The following is a description of a gene set: Human Gene Set: ZNF664_TARGET_GENES species: Homo sapiens from publication Yevshin I, Sharipov R, Kolmykov S, Kondrakhin Y, Kolpakov F (PMID 30445619) Genes containing one or more binding sites for (ZNF664) in their promoter regions (TSS -1000,+100 bp) as identified by GTRD version 20.06 ChIP-seq harmonization., and this is the list of marker genes: SMG7, FSBP, SEPHS2, IFNAR2-IL10RB, HMGXB4, TSR2, CCDC65, SVBP, TRIM44, DPY19L4, UACA, GNAO1 (G protein subunit alpha o1), CAMSAP1 (NCBI Gene Id 55490), PPP1R12A, FDPS, POMT2, IMPACT, HCFC2, DENND2B-AS1 (DENND2B antisense RNA 1), DNMT3B, KIF9, STAT2 (NCBI Gene Id 6773), VMAC, DAGLB, RABGGTA, DOC2A (NCBI Gene Id 8448), INSYN2B, LAG3, RNU4-60P, PLAC1, PI16, INAVA, ALDH3A1, TTLL13, MRPL11, CTSB, HOMER1, PDRG1, TATDN2, CYFIP2, BICDL2, NHSL3 (NHS like 3), DHX9, JAK2, NUP37, PTGES3L-AARSD1, EHHADH-AS1, CLASP2 (cytoplasmic linker associated protein 2), VEPH1, LAMP1, LINC00431, PRSS23-AS1, LINC02028, NUTM2B-AS1, FTO, TIA1 (TIA1 cytotoxic granule associated RNA binding protein), TFDP2, ZFYVE27, RHEBP2, CCSAP, EFCAB13-DT, LINC02522, LINC01641, TAF15, LIPM, POLK, IFTAP, LYPLAL1-DT, GBA1, LINC02860, EXOSC2, ARHGAP40, LINC00682, CACYBP, KDM5C, TNRC18, ARHGEF12, VRK1, VEGFA, CNOT10, PI4K2A, RNF114, GADD45GIP1, PAFAH1B1, WASHC2A, CGNL1, MRPS31, TTYH2, MIR5696, MIR1273C, TERF1, NLRC5, ARHGAP26 (NCBI Gene Id 23092), CLDN23, FABP5, LINC00845, CHD9, CEP350, RN7SL241P, STON2, CCAR2, CCNL1, MIR615, LMBR1L, ZNF827, RALGPS2-AS1, RALA, HIRIP3, IFI6, RAB35-AS1, PCAT6, DCTN1, EMC9, GXYLT2, TMPRSS6, ZNF408, MTG2, ZNF565, ZNF609, TSPAN31, GALNTL5, DLEU1, ELFN1-AS1, PSMD3, MLST8, EPS8L1, GTPBP3, ANKRD18B, GABARAP, RAX2 (NCBI Gene Id 84839), UTP23, PHF3, PRPF40A, LINC02044 (NCBI Gene Id 101929717), SPMIP10, NFYC, SYNGR1, ODAD4, CAMK1, ABLIM2, CFAP97D1, NCOA2, GOLPH3L, ZNF263, PDE2A, INTS14, NRBP1, HOXC12, LMO4, RPL32P18, EGLN2, ACOX2, PTCH1, CDKAL1, COX6B2, FRMD4B, WEE2-AS1, ERICH1, HAPLN2, DSE, OSBPL3, DNPEP, PCDH12, ADAMTS14, RAB5A, SMCHD1 (structural maintenance of chromosomes flexible hinge domain containing 1), IFI35, YAE1, LINC02435, LHFPL2, PBX1, DDX5, TRIM62, OR1X5P, TRUB2, SSX2IP, MAPK4, SCN4B, LNROP, BEGAIN, B4GALNT1, MECR, RAPGEF3, CRISPLD2, BORCS6, PEAK1, TTYH1, GRPEL1, NOL12 (nucleolar protein 12), SPAG5, CELF1 (NCBI Gene Id 10658), TJP3, PHC2, AQP8, RPUSD2, EYA2, PDK2, DEFB124, HADH, HMGN2P15, CHD2, USP3, STX8 (syntaxin 8), PDZRN3-AS1, CAMK2G, ENSG00000181123, CHEK2, RERE, IGDCC3 (NCBI Gene Id 9543), COPS3, TIMP1, TPM4, IGFL4, TMEM167A, ARHGEF2, AP3B2, PAM16 (NCBI Gene Id 51025), GMNC, RPSAP10, KLHDC9, LINC00940, SERTAD3, KAT8, LMNA, CD160, HERPUD1, RHEBP1, DAPP1, LIF-AS2, RAB27A, DNHD1, CACNG5, LAMTOR5, PFKFB4, RPP25L, OCSTAMP, SMAP2, RPS6KC1, BCL10, BCL7C, DOHH, ENSG00000255428, CERT1, ITGA7, RBMS1, HACD3, GAPDHS, EIF3F, LIPA (NCBI Gene Id 3988), CARD8-AS1, CAMSAP2, COX16, PDE4A, ADD3, FZR1, LTBP4, MDGA1, PRPSAP2, SNORD96A, MIR4799, ATP23, CDC42EP4, FN1, KDM5B, NEK7, MAN1C1, HNRNPR, SEC22B, CHORDC1, CROCCP3, GRM8, CCNG2, SEC22C, IGSF23, ARHGAP23, GDAP1, PTGR2, MEI1, ZNF865, KIF12, TOR1A, LRP10, ISY1, RNU2-17P, PYY, RBM14-RBM4, SUB1, MED25, HMGA2-AS1, CREBRF, HMGN3-AS1, CWC15, RAI14, GTF2E1, ARL2BP, CALCOCO2, ANKRD13C, ATF2, RN7SL443P, CAPZB, CCDC168, ARHGEF10L, KLHDC8A, SNX27, LINC00963, SLC12A8, PNPLA6, MIR6124, PGAM1P5, TMEM253, TMEM128, SEZ6L2, PADI2, TEFM, DAZAP1, MECOM, TIMM17A, MIR99AHG, TRIM59, NOSIP, MTMR4, DAPK3, KCTD3, CLASP1, SRSF10, TNFRSF12A, CREM, CLN6, SH2B3, FRG1, BRMS1L, CDK17, CHRM4 (NCBI Gene Id 1132), USP30, RRAS2, TOR1AIP2, CCNQ, ADGRV1, MAP1S, ZMAT2, CBFB (NCBI Gene Id 9163), FBXO17, SLFN12, GANC, SBF2, QSER1, FAM174B, SGSM1, PRMT1, DTNA, EPHB6, TBC1D4, CPD (carboxypeptidase D), ENSG00000236366, SRP54-AS1, MTA3, COG5, ZMPSTE24, EIF3I, SMG8, FANCD2, LNMICC, TRAF3IP2-AS1, MRPS15, SOS1, SLC5A5, PGF, LINC01116 (NCBI Gene Id 375295), WDHD1, NEK2-DT, ANO1, LIG1, WDR24, MYB, H2AZ2, SLC15A3, LMO1, MAT2B, ZNF503-AS1, RHEX, ST7-OT4 (NCBI Gene Id 338069), FNDC4, SAMD8, ATP6V1G2, TTC1, JAKMIP1, MICOS10-DT, COPS5, ACTN4, SLC4A9, TAF6L, OLFM1, EPB41L2, CNNM4, MAPK6, PDCD11, KDM1B, RPL18, ST7, C11orf58, FBXO31, DHRS13, IQCN, BRWD1, LINC02229, NEURL1B, RNU7-29P, MTUS2, PPL, CLEC2L, LNCRNA-IUR, CD276, MGC16275, GNAO1-DT, WSCD1, TOR2A, SCUBE1, DR1, OMG, DCAF11, TMEM234, GTF2H4, GLT8D2, HIF1A, STX4, CARD10, RNF150, CEP95, PLEKHM1, NLGN1, MACF1, SPACA4, CEBPB-AS1, FHL1, PHB1P18, RILPL1, STRN3, ABHD6, XPR1, ATRX, PLA2G1B, NIPA1, RUNDC1, EPS15, PRKCI, TMED2-DT, C19orf25, CHD7, CDC5L, FUZ, ATP5F1C, RPL36, ZDHHC7, RBM39, ENSG00000265246, TSNAX, C14orf132, SYNDIG1L, GAS8, ANKIB1, C16orf96 (chromosome 16 open reading frame 96), PML, MRPL39, FOXM1, PLXDC1, HEXA-AS1, FAM20B, CATSPERD, RBBP6, OPA1, ZNF579 (NCBI Gene Id 163033), MIR5003, LINC01503, RNU6-821P, CDC42SE1, PRPF40B, SEMA4B, HES4, ITSN1, CXADR, CWC25 (NCBI Gene Id 54883), PLEKHB2P1, SLC25A53, C16orf95-DT, KAAG1 (kidney associated DCDC2 antisense RNA 1), CTNNBIP1, LINC00856, MAGED1, ZNF277-AS1, WFIKKN2, BSPRY, FMN2, LINC00173, GABRD, NDUFA11, COL17A1, ENPP3, HMGA2, ALAD, ZC3H13, CCDC9, AGTRAP, MAPKAP1, ISLR2, ARHGAP24, GLMN, MTFMT, IL16, CXorf38, MIR4425, RASAL1, BLM, KIFAP3, NOL6, TXNRD2, MAPK14, SLC39A13, GBA1LP, ADAP2, XKR8, AFG3L2 (NCBI Gene Id 573970), PLLP, TMCO4, RND1 (Rho family GTPase 1), PHOSPHO1, MRPS21P6, TSHZ2, ANKRD31, MEF2A, PLEKHA7, CPVL, LINC01944, GLIPR1L2, PALLD, SEPTIN7P14, HMG20A, CARD8, RACK1, LYPD3, MPRIP, GMDS-DT, FUBP1, PTGES3L, GIT2 (GIT ArfGAP 2), SNHG16, URI1, VLDLR-AS1, OSTN, FAM181B, MYH14, TMEM98, RN7SL417P, LUZP1, MTFR1L, TARS2 (NCBI Gene Id 80222), KLHL36, LNCATV, AATF, PRMT5, SH2B1, PPP2R2A, FRMPD2, TLCD5, SLC9A6, PAXBP1, NR2F1-AS1, TRIB3, TUBA1C, NUTM1, SRFBP1, BPNT2, IFT74, ENSG00000260592, TMEM260, ZBTB43, MOV10, C3orf38 (NCBI Gene Id 285237), TMEM44-AS2, RNU2-33P (NCBI Gene Id 106480211), MRPS18CP6, DTX1, GPR132, RDH8, WASF4P, NTF4, VPS39, SDC4, ZNF596, ASB11, SCAPER, TPCN1, LINC01298, EEF1A1, ACSS2, CALM2, GLO1, STX12, NDUFB2-AS1, SUPT4H1, PHYH, GNPAT (glyceronephosphate O-acyltransferase), GDF15, PIGBOS1, PLN, VPS33A, CYTH4, FBXW8, HNF4A, CLK3, ELF3, HECTD4, HDAC5, ARL2-SNX15, STK19, AKR1B1P1, RPL32P27, LINC01411, ALDH9A1, NRL, PTX3, SMG7-AS1, LOXL2-AS1, ECE1, RHOF, SERAC1, PHGDH, UPF1, LYRM9, POLQ, WNT8A, C2orf42, PLXNC1, STK4, TLE2, LRRC51, RNF149, GALNT9, AP3S2, CYB5R3, PLA2G4C, ANK2, MIR4487, LIM2-AS1, SORBS1, KDM1A, RLIM, WWP2, SVIP, DCP2, DBF4B, TM7SF3, THYN1, KMT2C, MANSC1, RAB3D, UFC1, NOP2, RANP5, ZC3H18, RN7SL734P, EPCIP-AS1, PEX19 (NCBI Gene Id 7835), ZBTB38 (zinc finger and BTB domain containing 38), HPS6, ITPR1 (NCBI Gene Id 619543), RPL23AP53, ZNF296, KCTD9 (NCBI Gene Id 54793), RAP1GAP, EGFLAM-AS1, TNNI1, IL17B, LINC00921, TRAV41, LINC01270, STRA6, SRSF12, C2-AS1 (C2 antisense RNA 1), ITGAL-AS1, PIK3R2, NAPSA, PFDN1, NOS3, A1BG, SF3A3, GABPB2, ZSCAN23, BLOC1S1, SIPA1L3, CASP9, SLC4A1AP, DYNC2I1, ABCA7, TRAF4, LYPD5, TNKS1BP1, ANKRD34A, SPCS2P4, GLG1, CCDC91, KCTD17, TMED2, SYVN1, ZYG11A, REV3L, CHMP3, FABP5P3, MIR608, SAMTOR, MANEAL (mannosidase endo-alpha like), NAGA, ADGRA3P1, SMAGP, THORLNC, MRTFB, RPS26, MFN2, LCP2, PDLIM4, REEP3 (NCBI Gene Id 221035), SNORD48, C16orf92, CORO1C, SMG1P7, RPL37, DOCK9, CAPN2, ARHGAP1, PCBD1, FAM20A, WDR11-DT (NCBI Gene Id 283089), SRC, TPMT, MAN2A1, ENSG00000244137, NFASC, TM9SF4 (NCBI Gene Id 9777), COMMD5, CEBPG, RN7SL209P, SHLD2P1, DNAJC7, SPRYD3, AJUBA-DT, TMEM87A, MIR5700, ABRACL, OPA3, DIRAS2, TGFB1, CD151, DDHD2, RAPH1, LOXL2, PDHB, DPRXP1, KCNK1, EXOC3, RGS22, ARHGEF19, HEXA, ZNF473, STK10, RABGAP1L-DT, C1orf131, CNOT6L, LTBP3, CDCA2, SNHG32, VPS41, RNF24, ADAM9, EFCAB7, ANO8, CRYM, EIF4G1, EFCAB14, AMFR, NOVA2, TTI2, GPR62, NR3C1, ENSG00000269172, MFSD14A, DNAH14, HNRNPMP2, SINHCAF, SLC38A1, C9orf78, SSBP2, ERCC1 (ERCC excision repair 1, endonuclease non-catalytic subunit), SPAG17, SMAD9, BBS7-DT, CALCRL-AS1, STAT6, TMEM248, LINC02453, NUCB1-AS1, ENG, LINC02687, REXO5, C9orf50, THUMPD3-AS1, GOLGA3, GREM2, TMC8, FGD6, ECE1-AS1, DPP9, ACER3, KLRK1, CUL2, ALDOA, SPINK2, ADA, RAD54B, MED21, SHC4, TENT5B, ISY1-RAB43, EXOSC3, RNU6-22P, MIR5092, SLC20A1, WDR11, ARHGAP18, USP6NL, LINC00910, TRIM15, CGGBP1 (NCBI Gene Id 8545), CCNI (NCBI Gene Id 10983), HCG27, LINC01132, EPB41, CASP8, ZBTB20-AS1, GTF2H5, FAM222A, TRIM9, WWC1, SNHG30, LYPLAL1, ZMPSTE24-DT, LINC02794, CDK5RAP1, ERAP2, RNU6-166P, MIR554, RPS14, ME2, SULT2B1, CHIC1 (cysteine rich hydrophobic domain 1), ENTPD4, CDA, MGST2, NDUFS7, SPATS2L, ADAR, SCFD2, SLC25A17, TSNAX-DISC1, SYNGR3, TAF1A-AS1, GON4L, TIAM2, TTC3, CFAP61 (cilia and flagella associated protein 61), VTA1, SPHK2, AJUBA, PHF21A, NUP42, ABHD17A, ZNF302, SPATS2, HNRNPD, FRMD7, MPL, ENSG00000238761, GPRC5B, CCT6B, QKI, PDPN, LIX1L, FES, RAB11A, ARHGEF7-AS2, LYPD1, ARL2, CRTC1, ARHGAP22, RN7SL16P, UCK2, DZIP1L, GPX8, PIGQ, LRIG1, FRA10AC1, KRT15, RBM14, CUX1, ITGB3BP, DMAP1, SLC29A2, DHX16, ISG15, MDM2, SUPT7L, AK8, SRBD1 (NCBI Gene Id 55133), CFAP52, CDHR17P, ENSG00000238966, PRELID3A, KRT18P12, SELENOV, MTF2, TICRR, R3HDML-AS1, PARP2, B2M, LASP1, RGS10, ATP2B4, FAM21EP, POLR3GL, GLB1L3, RGS16, DHTKD1, CCDC171, GRIP2, SIN3A, AS3MT, DUSP22, SSBP1, CLUL1, EXOSC9, BRF2, MED23, ANP32E, CPNE9, LAMTOR5-AS1, EEF2K, FRRS1, CSPP1, TRIM45, MAP1LC3B, DBR1, DXO, RRN3P1, RPSAP9, MAD2L1BP, CYSRT1, DENND4A, LINC01392, RBBP5, CFP, VARS2, TSPAN33 (tetraspanin 33), NDFIP2, SLC24A1, H2AZ2-DT, PDE11A, ZNF438, MAN2A2, SERTAD3-AS1, DES, NOP16, MEX3A, EGLN1, USP34, NOP10, LBX1-AS1, DHX29, SNORD13, PRICKLE2, TMEM245, COPG1, RAP1A, HPS4, POMGNT1, PAFAH2, NDEL1, MAP7D1, GNAL, NUTM2A-AS1, ARHGAP15, NMNAT1, ZNF395, TMEM202-AS1, GTF2IP12, LIMCH1, LINC00938, PDGFC, CIBAR2, STK4-DT, MTO1, GREB1, CCDC120, RN7SL736P, BCL10-AS1, SPEG, PPP1R37, ATP5F1A